The following is a description of a gene set: studied in species Homo sapiens Human Gene Set: HP_ABNORMAL_MUSCLE_FIBER_TYPE_DISTRIBUTION Abnormal muscle fiber-type distribution Ay deviation from the normal distribution of fiber types in skeletal muscle. The skeletal muscle groups of the mammalian body are made up of bundles of muscle fibers. These fibers can be assigned to different Types, with characteristic movement rates, response to neural inputs, and metabolic styles. Skeletal muscle fibers are broadly classified as slow-twitch (type 1) and fast-twitch (type 2). Multiple fiber types are generally intermingled within a single muscle group, and different muscle groups have varying proportions of fiber types, and this is the list of marker genes: ACTN2, RAPSN, VCP, SLC5A6, TNNC2 (troponin C2, fast skeletal type), LRP12, STIM1, SMN1, SPTLC1, UNC45B (unc-45 myosin chaperone B), TWNK, SPEG, DOK7, MYPN, TAMM41, DNM2, SELENON, KY, FXR1, LMOD3, GDAP1, BIN1, TPM2, CCDC78, CHRNE, COQ5, HMGCR, RYR1, NEB, KLHL40, YME1L1, AGRN (NCBI Gene Id 389836), MYH7, ANXA11, MYH14, POMT1, POLG, CLCN6, TPM3, TTN, LAMB2, PNPT1, GYG1, KBTBD13 (kelch repeat and BTB domain containing 13), AK9, CFL2 (cofilin 2), MAP3K20, FBXL4, DYNC1H1, KCNA1, ACTA1, FKBP14, KLHL41, OBSCN, MYL1, CAV3, COLQ, MTMR14, POLRMT, MB, COL6A1, DPAGT1, GARS1, CHRND (NCBI Gene Id 1144), COL13A1, CHRNA1, AGTPBP1, SGCG, LRP4, RYR3, SCN4A, MYF6, TNNT1, EMILIN1, GMPPB, ALG14, REEP1, CHRNB1, SLC25A12, ALG2, MUSK, GFPT1, MYH2